The following is a description of a gene set: Genes up-regulated in comparison of control conventional dendritic cells (cDC) at 2 h versus cDCs infected with Newcastle disease virus (NDV) at 2 h. The dendritic cell (DC) is a master regulator of immune responses. Pathogenic viruses subvert normal immune function in DCs through the expression of immune antagonists. Understanding how these antagonists interact with the host immune system requires knowledge of the underlying genetic regulatory network that operates during an uninhibited antiviral response. In order to isolate and identify this network, we studied DCs infected with Newcastle Disease Virus (NDV), which is able to stimulate innate immunity and DC maturation through activation of RIG-I signaling, but lacks the ability to evade the human interferon response. To analyze this experimental model, we developed a new approach integrating genome-wide expression kinetics and time-dependent promoter analysis. We found that the genetic program underlying the antiviral cell state transition during the first 18-hours post-infection could be explained by a single regulatory network. Gene expression changes were driven by a step-wise multi-factor cascading control mechanism, where the specific transcription factors controlling expression changed over time. Within this network, most individual genes are regulated by multiple factors, indicating robustness against virus-encoded immune evasion genes. In addition to effectively recapitulating current biological knowledge, we predicted, and validated experimentally, antiviral roles for several novel transcription factors. More generally, our results show how a genetic program can be temporally controlled through a single regulatory network to achieve the large-scale genetic reprogramming characteristic of cell state transitions. from publication Zaslavsky E, Hershberg U, Seto J, Pham AM, Marquez S, Duke JL, Wetmur JG, Tenoever BR, Sealfon SC, Kleinstein SH (PMID 20164420) Human Gene Set: GSE18791_UNSTIM_VS_NEWCATSLE_VIRUS_DC_2H_UP studied in species Homo sapiens, and this is the list of marker genes: CACNG5, CCZ1, PAFAH1B2P2, GABRB2, MYG1, C7, CSPG5, POM121L12 (POM121 transmembrane nucleoporin like 12, NCBI Gene Id 285877), BTNL9, RAMP3, KRT33B, HNF1B, PARD6B, CT55, ODAD3, VXN (vexin), NOVA1, PGK2, ANKRD36C, ENSG00000291211, FAM229A (family with sequence similarity 229 member A), CLN3, ASS1 (NCBI Gene Id 445), STAP2, KDELR3, FOXF2, CRB2, SPRR4, SHCBP1L, CNFN, VN1R3, PRB1, KIF24, P4HA3, PNPLA1, TUB, NALF1, LEFTY2, ZNF527, NEK2, PAX9, DIPK1C, PAX6, ENSG00000284691, RNF182, ENSG00000257176, MAEL, CRISPLD1, LIPE, NAV2, LINC00652, ART5, PAEP, COL13A1, PBX1, ASF1A, NEUROD4, MOV10, SLC5A10, EFCAB5, PPP5D1P, RBM20, MGC15885, RPS6KA6, MAPT, AGTR2, KRTAP5-2, MIEF2, KCNIP2, PRSS36, DSCAM, GRPR, PDGFD, RFPL1S, PRKAR1B, PTPRT, NPAP1, KLRC3, NTM, FBXL2, CCDC3, TNP2, SYPL2, TMEM177, ZBTB22, LRFN2, GARNL3, GALNT17, TBC1D8B, ZNF556, LINC01512, LINC02901, AQP1, HECW1, IL13RA2, STK32A, UBE2NL, AGXT2, TSPAN3 (tetraspanin 3), ZNF628, TRIM50, ZDHHC15, FGF13-AS1, ANO4, TMC1, FAM181A, LINC01354, HTR3A, ELSPBP1, LINC01553, RNASE11-AS1, PURG, USP5, SNTG2-AS1, SLC4A1, RGS4, FRMD5, HELLS, RGPD4-AS1, NPR2, KIF26A, TSPAN18, KRTAP19-1, BCHE, LINC00689, WNT7B, HTN3, PBX3-DT, FGFBP3, OPN4, APOC3, IQUB, ACHE, CAMK2B, C10orf53, VIPR2, ZNF491 (NCBI Gene Id 126069), PDCD2L (programmed cell death 2 like), LINC01530, CNTNAP3B, KRTAP4-7, LINC00315, INTS5, SALL3, FGF16, SULT1B1, GALR3 (galanin receptor 3), PDE1A (NCBI Gene Id 5136, phosphodiesterase 1A), STPG4, KRTDAP, PLPPR5, SLC22A24, CSN1S2AP, TRIM61, TTLL11, CFAP54, CTSE, MECR, H1-1, MGP, FBXO43, OR5L2, CDKN2A-AS1, SCARA5, DNAH9, ENPP7, LINC00052, ASPHD1, DNMT3B, SIGLEC16, CPZ, GCSIR, ABO, MAGEA10, SCAMP2, SERTAD4-AS1, MLPH, LGALS13, KRT35, CCNT1, FBXL18, RGMA, KIR2DS3, LCN2, RNF26, ZSCAN31, ANGPT4